Given this list of marker genes Adgrg3, Eif2ak4, Foxp3, Msx2, Sik1, here is a description of the gene set: Mouse Gene Set: GOBP_NEGATIVE_REGULATION_OF_CREB_TRANSCRIPTION_FACTOR_ACTIVITY Any process that stops, prevents, or reduces the frequency, rate or extent of the activity of the transcription factor CREB. studied in species Mus musculus